The following is a description of a gene set: The process whose specific outcome is the progression of the mammary gland over time, from its formation to the mature structure. The mammary gland is a large compound sebaceous gland that in female mammals is modified to secrete milk. Its development starts with the formation of the mammary line and ends as the mature gland cycles between nursing and weaning stages. Human Gene Set: GOBP_MAMMARY_GLAND_DEVELOPMENT studied in species Homo sapiens, and this is the list of marker genes: HOXA5, USF2 (upstream transcription factor 2, c-fos interacting), CAD, DDR1, BAX, ATP2C2, TGFA, FGF2, HK2, SOSTDC1, ZNF703, WNT5A, WNT3A, TBX3, MTCO2P12, SOX9, ELF5, SCRIB, PERP, GLI2, MT-CO2, GPAT4, IQGAP3, RXFP1, PML (PML nuclear body scaffold), STAT6, LBH, RREB1, SLC6A3, NME1, PTCH1, NRG3, CEBPB, TBX2, ESR1, TGFBR2, BSX, ETV5, HOXA9, BTRC, ITGA2, CAPN1, ORAI1, CYP19A1, GLI3, CSMD1 (NCBI Gene Id 64478), CCND1, PHB2, AR, WNT2, AREG, MSX1, IGF1, GATA3, CAV1, KDM5B, CAV3, HOXB9, PYGO2, CREB1, FOXB1, NOTCH4, ARHGAP35, PRL, PRLR, OXTR, VEGFA, GHRHR, OAS2, XBP1, SMO, NTN1, EGF, EPHA2, MAPK1, HIF1A, RTN4, FGFR2, BRCA2, ID2, JAK2, VDR, AKT2, TNFRSF11A, SRC, BMP4, MSX2, NRG1, TGFB1, APLN, ERBB4, XDH, CDKN2A, AKT1, ROBO1, NCOA1, GPX1, CCL11, WNT3, FASN, NR3C1, CSN3, HOXD9, STAT5A, ELF3, SOCS2, ATP7B, NFKB1, CSF1, FGF10, TGFB3, IRS2, IGFBP5, STAT5B, ZBTB7B, NCOR2, TPH1, WNT4, UPRT, TFAP2C, WNT7B, CDO1, DEAF1, TNFSF11, MED1, BCL2L11, CSN2, CSF1R, IRF6, NEURL1, ABCB1, PGR, LRP5, FOXF1, SLC29A1, CRIPTO, LEF1, ARHGAP5, MTX1, LATS1 (NCBI Gene Id 9113)